Given this list of marker genes Trim12c, Trim30b, Cd74, Trim12a, Hs3st5, Ppie, Axl, Trim30a, Plscr1, Kpna6, Ptx3, Trim11, Trim30c, Vps4a, Ubp1, Hmgb1, Hexim1, Slpi, Banf1, Top2b, Zfp36, Ifih1, Adar, Stau1, Trim25, Ifitm6, Stat1, Tsg101, Ifi206, Apcs, Tarbp2, Trim13 (NCBI Gene Id 66597), Larp7, Ddx5, Zc3hav1, Notch1, Top2a, Trim21, Eif2ak2, Gm11772 (predicted gene 11772), Ch25h, Trim27, Crebbp, Dynlt1a, Ifi208, Pfn1, Cnot7, Oas1c, Tbc1d20, Znfx1 (NCBI Gene Id 98999), Ifi207, Cd4, Ifi213, Fmr1, Tasor, Pkn2, Dicer1, Nr5a2, Ifitm2, Tmprss2, Trim30d, Tmem250, Trim28, Tmem39a, Ifi203-ps, Atg12, Trim38, Cd209c (CD209c antigen), Oas3, Ccl5, Ifitm3, Dynlt1b, Ltf, Oas1g, Trim14, Fam111a, Ifi203, Srpk1, Trim62, Mid2, Mndal, Pde12, Stom, Mphosph8, Ifnl3, Bcl2, Trim6, Vps37b, Oasl2, Tnf, Dynlt1f, Mir378a (microRNA 378a, NCBI Gene Id 723889), Cd209e, Ifi209 (interferon activated gene 209), Apobec3, Ifitm1, Lamp3, Ddb1, Kpna2, Shfl, Larp1, Zfp809, Ppid, Isg15, Rsad2, Hmga2, Smpd1, Mx2, Fkbp6, Trim15, Lgals1, Ifnb1, Cd209d, Vapb, Aicda, Nectin2, Dhx9, Morc2a, Ark2n, Trim5, Clec4g, Setdb1, Mbl2, N4bp1, Isg20, Map3k1, Mir93 (microRNA 93), Oas1d, Ilf3, Mdfic, Cxcr4, Dynlt1c, Oas1f, Gbp7, Trim31, Oasl1 (2'-5' oligoadenylate synthetase-like 1), P4hb, Oas1b, Ifi214 (NCBI Gene Id 545384), Ppihl, Trim8, Tmprss4, Oas1e, Oas1a, Adarb1, D1Pas1, Oas2, Sp100, Hacd3, Bst2, Mavs, Atg5 (NCBI Gene Id 97669), Mir24-2, Prox1, Morc2b, Csnk2b, Mir24-1, Tyro3, Ppia, Ppih, Ifitm7, Bsg, Oas1h, Rsf1, Trim32, Rab7, Larp7-ps, Rnasel, Inpp5k, Rad23a, Furin, Srpk2, Ddx3x, here is a description of the gene set: species: Mus musculus Any process that modulates the rate or extent of the viral life cycle, the set of processes by which a virus reproduces and spreads among hosts. Mouse Gene Set: GOBP_REGULATION_OF_VIRAL_PROCESS